The following is a description of a gene set: studied in species Homo sapiens Human Gene Set: GOCC_MPP7_DLG1_LIN7_COMPLEX A heterotrimeric protein complex formed by the association of MMP7, DLG1 and either LIN7A or LIN7C; regulates the stability and localization of DLG1 to cell junctions., and this is the list of marker genes: LIN7B, DLG1, MPP7, LIN7C, LIN7A (NCBI Gene Id 8825)